Given this list of marker genes Mecr, Cyp1b1, Alox12, Hacd2, Dbi, Thrsp, Pon1, Akr1c21, Acot2, Hacd1, Eci1, Slc27a2, Aloxe3, Acot8, Akr1c20, Alox5ap, Elovl7, Cyp1a2, Dpep2, Gpx1, Hsd17b8, Acad10, Elovl5, Cyp2j6, Ehhadh, Them4, Acaa1b, Acox3, Scd1, Cyp4f39, Acot5, Alox8, Cyp2c66, Eci2 (enoyl-Coenzyme A delta isomerase 2), Ptgs2, Ptgis, Akr1c18, Mid1ip1, Acbd6, Cyp4a10, Cyp4a30b, Cyp4b1, Cyp1a1, Cyp4a31, Elovl2, Acsl4, Cyp4f18 (NCBI Gene Id 72054), Slc22a5, Alox12b, Hadha, Ptges2, Cyp8b1, Elovl3, Akr1c14, Faah, Tecrl, Awat1, Cpt1b, Acot4, Gpx2, Ephx2, Mcee, Acox2, Cyp2u1, Tbxas1, Decr1, Abcd1, Acbd5, Morc2a, Decr2, Acsl6, Amacr, Alox15, Akr1c6, Acadvl, Acsf2, Hsd17b4, Acbd7, Mlycd, Pon3, Cyp4a29, Acot3, Ltc4s, Acot13, Cyp2c65, Lta4h, Cyp4a12a, Cyp4f40, Acot7, Akr1c13, Dpep1, Ptgs1, Hpgds, Ggt5, Cpt2 (NCBI Gene Id 12896), Gpx4, Hacd4, Cyp4f15, Hsd17b3, Ptgds, Crot, Ggt1, Acsf3 (acyl-CoA synthetase family member 3), here is a description of the gene set: species: Mus musculus This event has been computationally inferred from an event that has been demonstrated in another species.<p>The inference is based on the homology mapping from PANTHER. Briefly, reactions for which all involved PhysicalEntities (in input, output and catalyst) have a mapped orthologue/paralogue (for complexes at least 75% of components must have a mapping) are inferred to the other species. part of: Metabolism of lipids Reactome Pathway: Fatty acid metabolism electronically inferred by orthology from the curated human pathway